The following is a description of a gene set: from publication Cao J, O'Day DR, Pliner HA, Kingsley PD, Deng M, Daza RM, Zager MA, Aldinger KA, Blecher-Gonen R, Zhang F, Spielmann M, Palis J, Doherty D, Steemers FJ, Glass IA, Trapnell C, Shendure J (PMID 33184181) The gene expression program underlying the specification of human cell types is of fundamental interest. The study authors generated human cell atlases of gene expression and chromatin accessibility in fetal tissues. For gene expression, the study authors applied three-level combinatorial indexing to >110 samples representing 15 organs, ultimately profiling ~4 million single cells. The study authors leveraged the literature and other atlases to identify and annotate hundreds of cell types and subtypes, both within and across tissues. Our analyses focused on organ-specific specializations of broadly distributed cell types (such as blood, endothelial, and epithelial), sites of fetal erythropoiesis (which notably included the adrenal gland), and integration with mouse developmental atlases (such as conserved specification of blood cells). These data represent a rich resource for the exploration of in vivo human gene expression in diverse tissues and cell types. Human Gene Set: DESCARTES_MAIN_FETAL_METANEPHRIC_CELLS studied in species Homo sapiens Marker genes curated from the annotated cluster as represented in the Descartes Human Gene Expression During Development database., and this is the list of marker genes: DENND5B, TRABD2B, LYPD1, HOXA11-AS, SLC12A1, HOXA9, TRPA2P, HOXC8, UMOD, HAGLR, BMPER, FLJ12825, CLEC18B, SINHCAF, DMRT3, SOST, EYA1, MYHAS, LINC02242, LINC02253, XRCC6P4, SHISA8, CEP164P1, SELENOV, THEM7P, COL13A1, HOXD1, LINC01159, HOXC-AS3, HOXC11, ENSG00000228033, C1QTNF7, NPHS2, LINC02893, SIX2, HOXC10, LINC01781, WASF3 (WASP family member 3), SLC34A1, HSPE1P13, ADAMTS20, HOTAIR, FGF8, KCNJ1, LINC01539, SLC13A1